Given this list of marker genes Mxi1, Mkrn1, Nfkbiz, H2ac6, Kcnab2, Kras, Ncdn, Mrps36, Pax6 (NCBI Gene Id 18508), Pop5, Slain1, Rev1, Kcnk3, Gpc4, Snord59a, Rps28, Ubc, H2ac8, Ubqln4, Iqcg, Actr3, Cracdl, Tha1, Znrf1, Steep1, Hcfc1, Sanbr, Six2, Itm2b, Smarcd1, Dcp2, Trip12, Axin2, 4930519P11Rik, Wnt2, 4930580E04Rik, Foxj3, Schip1, Spred1, Psmb4, Rcn1, Slc25a36, Stam, Kbtbd8os, As3mt, Mir100hg, Slco1a5, Prickle1, Ccdc142os, Ipo7, Cyth2 (cytohesin 2), Snhg3, Med13l, Gclc, Gcn1, Med16, Snhg15, Zfp148, Gm26562, Rps20, Tmem135, Rmi1, Zfp219, Ptpa, Lrrc58, Bend7, 6530409C15Rik, Hmox2, Fam53c, Gps2, Gatad1, G3bp2, Elk4, Gpld1, Adam9, Mir150, Srsf6, Syncrip, Lypd6b, Sinhcaf, Dffb, Aadat, Dhrs7, Marchf7, Tarbp2, A730035I17Rik, 2700078F05Rik (RIKEN cDNA 2700078F05 gene), Tshz3, Gstm5, Gm12694, Ccdc97, Foxo3, Gpd2, Btf3l4, Kmo, Pigm, Srsf2, Gm22579, Lamtor2, Rif1, Ptpra, Pcbd2, Gm22744, Snord12, Cfap43, H2bc6, Slc38a2, Pbx2, Arid1b, Ep400, Dennd1a, Sipa1l1, 1500026H17Rik, Gtdc1, Slc3a2, Emx2, Zfp524, 4933406P04Rik, 5330439K02Rik, Slc37a3, Jmjd1c, Mirlet7i, 1700084C06Rik (NCBI Gene Id 76618), Garem2, Phf8, Tunar, Numbl, Nfatc4, Zic2, Gm16249, Irak2, Zbtb34, Slc35d1, Tektip1, Birc6, Syce2, Zfx, Fbxo16, B3galt4, Ubqln1, Kank3, Zc3h12a, Pole4, Xiap, Mir6935, Pigl, Fignl1, Shisa5, Ppp1r10, Tet1, Oxsm, Dab2ip, Psmc3, Fance, Ehmt2, Smc5, Cenpu, Rom1, Arhgef11, Pde8a, Lsp1, Txnl4a, Set, Nadk, Mgat5b, Arhgap12, Gm9484, Prrg4, Umps, Prkd3, Gnptab, Prr14, Adnp, Btf3, Tdrd3, Fgfr2, Pdcd2l, Agps, 2310001K24Rik, Canx (calnexin), Gm15417, Tk1, Mest, Slc22a23 (solute carrier family 22, member 23), Sap25, Cdc42bpa, Mcl1 (NCBI Gene Id 99928), E130307A14Rik, Cfap276, Snord65, Paics, Fam163b, Rps10, Dio3, Ranbp17, Kdm2b, Chpt1, Gm6556, Epha2, Tfcp2l1, 1110025M09Rik, Mfsd4b5, Gm9884, Rybp, Dhx32, Srsf4, Mxra7, Rbm4b, Tob2, Zfp341, Rdh10, Fam78b, Cdx1 (caudal type homeobox 1), Mnt, Snora17, Gm23639, Gpr68, Dab2, Emx1, Ung, Psmb8, 1110059E24Rik, Ube2d3 (ubiquitin-conjugating enzyme E2D 3), Mir5627, Ttc8, Clasrp, Platr22, Zmym4, Hyal3 (NCBI Gene Id 235600), Gm11335, Arl2bp, Hectd2os, Ate1, Ext1, Gm25894, Pex2, Rpl21, Ctr9, Pdss2, Prmt3, Mtmr2, Cnot6, Clint1, Bcas2, Atxn2l, Nynrin, 4930520O04Rik, Slco5a1, Tnrc18, Arrdc3, Faah, Rad9b, Mroh8, Irak3, Maml1, Ints12, Insr, Etv5, Tyw5, Nudt1, Tmpo, Cisd1, Zfp326, Wtap, Vmp1, Limk1, Gm26590, Frmd8os, Shf, Parp12, Paqr8, Faap100, Tstd1, Brd2, Mmp25, 0610009L18Rik, Glcci1, Ppp1r35, Kansl3, Rcbtb1, Itsn2, Gm24016 (NCBI Gene Id 115490074), Stk38l, Fam120a, Nipa2, Pygo2, Fam135a, Acvr2b, Rps23rg1, Car7, Tusc2 (tumor suppressor 2, mitochondrial calcium regulator), Enkd1, Gm20544, Polr1b, Ep300, Ssbp2, Gm9958, Supt16, Kcnmb4, 3110031N09Rik, Gm10516, Zbtb38, Polr3g, Nln, Pcdh9, Agap3, Cyb5r1 (NCBI Gene Id 96900), Cnih2, Dleu2, Cdk4, Ino80dos, Tmem51os1, Fam162a, Hipk3 (NCBI Gene Id 15259), Ddx17, Snapc5, Rasal3, Slc23a3 (solute carrier family 23 (nucleobase transporters), member 3), Dexi, 4933431E20Rik, Flywch2, Sp1, Gm9828, Gm15270, Dhrs13, Gm10518, Kdm5b, Mcc, AU040320, Rmi2, Lamc2, Ccng2, Azi2, Pkp2, Sidt2, Slc12a2, Egln2 (NCBI Gene Id 97399), Ran, Zic4, C1ql1, Tinagl1, Sulf1, Sfxn5, Gm28047, Xpo1, Diaph1, Atp5mg, Sptbn1, Tm2d2, H2bc4, Adk, Tpm4, Ccdc9, Tfdp1, Tab1, Zfp24, Rnf19b, Fbxl3, Eif4enif1, 1110032F04Rik, Notch1, Iqank1, A230056P14Rik, Maf, Gatad2b, Lnx2, Acsl3, Rapgef2, Dnajb4, Psme1, Ftl1, Amotl1, Brd4, Arhgap21, Prrt2, Arid1a, Cul5, Neurl4 (neuralized E3 ubiquitin protein ligase 4), Slc25a4, Trib1, Dtx3, Dsg2, Dlgap4, Nod1, Abcc4, Picalm, Zfp407, Mapre1, Nhs, Cxxc4, Baiap2, Mgme1, Dock7, Med12l, Sgms1, Gm24452, Itgb1bp1, Gm16853, Map2k3, D17H6S53E, Alg1, Nol7, Gm43403, Siah2, Crot, Fam13b, 1700041G16Rik, Dusp1, Gm17501, Cnpy1, Bpnt2, Eapp (E2F-associated phosphoprotein), Socs5, Wwox, Oxct1, Fbxo30, Il33, Kcnq1, Gm24067, Npm3, Osbpl7, Gm24494, Prr14l, Tent4b, Snord45c, C920006O11Rik, Apoe, Hoxa4, Vamp5, Syt7, Tmem39b, Pdpk1, Slc30a9, Mettl5, Fblim1 (filamin binding LIM protein 1), Tulp4, Hnrnph1, Eif4h, Ggnbp2, Emx2os, Bcat2, Mir128-2, Ccnb1ip1, Rdm1 (RAD52 motif 1), Arid4b, Gm12279, Rps9, H2bc1, 4930432B10Rik, Atrx, Bcar3, Tor1aip1, Ermp1, Prrg1, Apex1, Utp3, Rplp0, Mecr, Zzz3, Adgrb3, Isca1, Ube2e1, Gm4419, P4ha1, Gm16253, Mrpl33, Prkacb, Defb44-ps, Kdsr, Bhlhe40 (basic helix-loop-helix family, member e40), Cirbp, 4933439C10Rik, Ptprj, Snx10 (NCBI Gene Id 71982), Tafa5, Bscl2, Adsl, Xpnpep3, Mplkip, Phykpl, Sgms1os1, Naa50, Psma4, Cnot1, Wrn (NCBI Gene Id 22427), Pxdn, Fermt2, Tcf12, Snrpe, Skil, Rere, Hes1, Apbb2, Gm57857, Slc10a7, Jarid2, Ugp2, Taf4, Rps19, Mex3c, Zfp82, Ncoa5, Pwwp3a, Sox5, Hes6, Zfp518a, Neat1, Chmp5, Rpl35a, Arid2, Ackr4 (atypical chemokine receptor 4), Wdr82, Cpsf3, Gnpda1, Dapk3, 3110082J24Rik, 4933440N22Rik, Ly6g6c, Gm16083, Gpr45, Plch1, Bloc1s2, Gm15631, Prcd, Zfp521, Zranb3, Hspa8, Atp2a2, U2surp, 5430416N02Rik, Hnrnpu, Cspp1, 1700113A16Rik, Bcl9l, Lrig2 (NCBI Gene Id 99941), Lemd3, Rabep1, Nid2, Ss18l1, Zcchc14, Amd1, Elapor1, Rgs6, Plcxd1, Znfx1, Washc1, Dnajb14, Elp5, Adamts10, Wasf1, Rabggtb, C030037D09Rik, Secisbp2, Gli1, Gm25878, 1810041H14Rik, Cux2 (cut-like homeobox 2), Rapgef6, Zfas1, Trp53cor1, Izumo2, Grcc10, Sclt1, Ahdc1 (AT hook, DNA binding motif, containing 1), Spmap1, Tmem181b-ps, Ptpn3, Naa12, Lrp12, Hapstr1, Rfc4, Atf7ip, Mir7036b, Snora65, Phactr1, Wdr5 (NCBI Gene Id 98832), 9330185C12Rik, Neurl2, Rnf146, Szrd1, Snord118, Cdk6, Rab26, Cnbd2, Brd10, Ptpn14, Pde8b, Rhbdf1, Gm11398, Acad9, Bin1, Ppp2r5e, Cdc42se2, Ptprr, Rbm47, Slc48a1, Scai, Thsd1, Midn (midnolin), Sra1, Gnb4, Cdh1, Kif20a, Med22, Arl6ip4, Isl2, Sec63, Chtf8, Gm22107, Foxk1, Man2a2, Ncoa2, Ninl, Gm16070, Sphk2, Gm5148, Cep104, 4930581F22Rik, Pan2, Ywhah, Gm10524, Ap3m1, Zmym3, Prrt1b, I830134H01Rik, Gm19569, Fbxw9, Meg3, Rusc2 (RUN and SH3 domain containing 2), Usp25, Zfp512b, Gpx4, Fut10, Smg5, 2410002F23Rik, Kif16b, Fbxo34, Pik3ip1, Eml3, Clcn3, Zfp384, Mex3b, Rhobtb3, Sspo, Gm23201, D130017N08Rik, Zfp609, Myl12a, Dnajc6, Rfk, B230354K17Rik, Aven, Zbtb16, Mir503hg, Galnt12, 1700086P04Rik, Scaf8, Mst1, Snord55, Mms22l, Cldn4, Ltbr, Bend5, Ttc41, BC005537, Man2c1, Polr1d, Supv3l1, Esrra, Nedd1 (NCBI Gene Id 17997), Eps15, Mybl1 (myeloblastosis oncogene-like 1), Nudt9, Reck, Acaca, Cplane1, Enc1 (ectodermal-neural cortex 1), Fhip2b, Slc35g1, Ywhaq, Ring1, Usp30, Mtcl1 (microtubule crosslinking factor 1), Hmga1, Spg11, Ribc2, Poldip3, Mrps18a, Tut7, Tbcb, Pls1, A730013G03Rik, Hexim2, Atp6v1a, Rnf26, Rab11fip2, Mir1247, Gm16701, Bltp3a, Sh3tc1, Ctnnb1, Slc6a8, Abi2, Malat1, Bcl7a (NCBI Gene Id 77045), Gsc2, H1f4, Gm15567, Paqr4, Lmln (NCBI Gene Id 239833), Cisd2, Acp6, Kdf1, Pbld2, Cd55, Mrm2, Caps2, 2500004C02Rik, Gapdh, Fahd1, Acvr1c, Gm15634, Ak4, Hsp90aa1, St7, Purg, Otx2, Ndufa7, Pik3c2a, Mir7687, Ankrd28, Spry1 (sprouty RTK signaling antagonist 1), Mllt6, Pim1, Unc5b, Purb (purine rich element binding protein B), Tmem168, Pakap, Zcchc4, Cerkl, Tmem229b, Evi5, Tmem121b, Mtdh, Mfsd4b3-ps, Fubp1, Dtnb, Arf1, Dll1, Syngr2, Snhg7os, Sugct, Mir9-3hg, Ipo5, Chd9, Lrsam1, Kcnj4, Rnps1, Lfng (LFNG O-fucosylpeptide 3-beta-N-acetylglucosaminyltransferase), Snx25, Cipc, Brd3, Sgcb (sarcoglycan, beta (dystrophin-associated glycoprotein)), Huwe1, A430035B10Rik, Gprc5c, Gm5447, 4933405L10Rik, 9230114K14Rik, Yipf2, Slc35b2, Ufsp1, 1700023H06Rik, Cux1, Timm21, 1600020E01Rik, Snora7a, Med1, Galnt2, Slc5a3, Neo1, Rtkn, Tpm1 (tropomyosin 1, alpha), Rpl13a, Gm25867, Qrich1, Dync2h1, Tpd52, Med29, Letmd1, Gm15723, Neurod1, 1700125H03Rik, Gm23301, Tbrg4, Iqcb1, Slc7a7, 2810433D01Rik, Thy1, Ocel1, Scmh1, Gm10244, Thap2, Sco2 (NCBI Gene Id 100126824), Slc44a1, Ccn1, Klhdc8a, Zfp628, Eif4e, Tenm1, Tbk1, Ube4b, Rbm22, Thra, Hsd17b4 (hydroxysteroid (17-beta) dehydrogenase 4), Zfp608, 1700028I16Rik, 9930012K11Rik, Rbm12, Akt3, Cep170b, Ppan, P2ry1, 1700045H11Rik, Greb1, Rcc1, Sh2b3, Helz, Zfp395, Gpr85, Foxp1, Cdkn1a, Ubb, Serinc3, Tle6, 4930430O22Rik, Rpl31, Snord72, Klf6, 6720483E21Rik, Slirp, Tsc22d4, Fam83h, Gm26330, Slc31a2, 2810408A11Rik, Sp3os, Patl1, Zfp710, Maip1, Cntnap2, Spr, Crebzf, Psip1, Ubtd2, Zfp597, Elac1, Suds3, Tssc4, Prdm15, Gm25855, Gpc6, Mtx3, Kmt2c, Bag1, Hnrnph3, Zfp423, Hexb, Scyl1, Rnf227, Epc1, Zfp335os, Mvb12b, 1700096K18Rik, Rtca, Pde5a, Mir762, Parp1, Paxbp1, Ndufb10, Zfp639, Ttc19, Polr2a, Bud13, Samd4, Bmf, Polr2i, Snord45b, E130018N17Rik, Gm11175, 4931440P22Rik, Tsku, Maml3, Col11a2, Depdc7, Aff1, Wbscr25 (Williams Beuren syndrome chromosome region 25 (human)), Igf2bp2, Smarce1, Upp2, Mfsd11, Swsap1, Rhobtb1, Wwp1, Hcfc2, Slc4a2, Epb41l4aos (NCBI Gene Id 69749), Ccn2, Slc4a11, Gm12743, Tead1, Atxn2, Donson, Gnas, Raver2, Smim14, Pank2 (pantothenate kinase 2), Adgrl2, Gm12474, C330002G04Rik, Alyref2, Inha, H4c1, Paox, 4930509H03Rik, Memo1, Rpl12, Ppp4r1, Lif, Cd164, Thoc3, Btg3, Ppip5k1, Snap91, Tmem191, H2ac11, Ash2l, Pabpc4, Esco1, Tlnrd1, Zfa-ps, Mir219a-1, Arhgap11a, BC031181, Gm24453, Atrnl1, Smad7, Gm16233, Crlf3, Syngr1, Tgfb1, 1700008O03Rik, Cdkn2aipnl, Gorasp2, Wrap53 (NCBI Gene Id 216853), Soat1, Aebp2, Fgf9, Mettl23, Gt(ROSA)26Sor, Efna4, Id3, Plcg1, E2f3, Epn1, Mrpl15, Setd5, Gm13375, Mapk9, Poln, Dynlrb1, Ppp1r15a, 2310005A03Rik, Agpat2, Atf7ip2, Gm10785, Mtg1 (mitochondrial ribosome-associated GTPase 1), Snord42b, Pard3, Gm14393, Rpl3, Plekha8, Mysm1, Fam168b, Bcl7c, Atp8b1, Azin2, Gm6658, Pccb, Mpc1, Ccnb2, Srp72, Sos1, Dcbld1, Xpa (NCBI Gene Id 22590), 2610005L07Rik, Ctdspl2, Bsg, Glyr1, Spred2, Tcf15, Mir1894, Fa2h, Ncor1, Snord58b, 4931406C07Rik, Zbtb7b, Inpp5a, Mtrfr, Smim1, Ccne2, Hsd17b8, Fbxo36, Celf2, Eif1, Chsy1, AU041133, Gtf2b, Adipor1, Caprin1, Rgl2, Utp14b, H2bc15, Gpr153, Nadk2, Ube2e3, Bsdc1, Zfp704, Sema6a, Cbx3, Gm23969, Mettl5os, Fxr2, Gm7160, Foxn3, Unc5a, Gm20609, Usp3, Ints10, Cntn4, Spry2, Arap2, Wipf2, Gm16124, Atp5f1b, Casd1, Ece1, Gm11627, Stamos, Rcl1, Vps29 (VPS29 retromer complex component), Man2c1os, Gab2, H3c10, Rpp21, Trap1, Ino80d, Atf7, Kmt5b, Ppp1r2, Hps5, Osgin2, Ctdnep1, Klhdc1, Sox2ot, Sephs1, Cdip1, A930001C03Rik, Taf4b (NCBI Gene Id 72504), Enah, A930032L01Rik, Plekha4, Cdc42ep3, Pafah2, Ppa2, Tbl1xr1, Ppp1cc, Rimoc1, Large1, Slc27a3, Dcc, Rpl18, Cdc40, Nrf1, Haus4, 2610035F20Rik, Rbm39, Poglut3, Capn7, Plk2, Lypla1 (NCBI Gene Id 18777), 4930592C13Rik, Gm11240, Dram1, Kcp, Gm9530, Srgap1, Klf10, Coro6, Irgm1, Kdm1a, Gm15860, Jpt2, Snord2, 2410006H16Rik, H2bc18, Relb, Crebl2, Rps27l, Zfp281, Cnot6l, Aplp1, Flywch1, Zdhhc6, Mov10, Rbpj, Coq3, Atic, Gm13033, Gm27003, Shld2, Gm15420, Htr7, Mpdz, Gm16740, Klf15 (Kruppel-like transcription factor 15), Ice1, Klhl35, Mettl1 (NCBI Gene Id 70215), Mapk11, Snora73b, Ngly1, Msh4, Clec12a, Eed (NCBI Gene Id 16759), Timmdc1, Tenm4, Fcor, Gramd1a, Atf5, Zmiz1, Foxp4, Klhl2, Arhgef12, Rpl18a, Epn3 (epsin 3, NCBI Gene Id 71889), Tmsb10, Tmem238, Kbtbd2, Pgls, Ndufs6, Ash1l, Tiparp (TCDD-inducible poly(ADP-ribose) polymerase), Rhbdd3, Prrc2a, Kcmf1, Iqsec1, Sdhaf2, Snord43 (small nucleolar RNA, C/D box 43), Mmgt2, Hdgfl2, Lmo4, Hagh, Gm13162, Skic8, Gm4707, Hspa9, Maz, Psma7, Arhgap42, Srgap3, Crem, Ctsa (cathepsin A), Uxs1, Slc15a4 (solute carrier family 15, member 4), Ddr1, Cdc73, Dap, Mix23, Mllt10, Guf1, Sec24d, Mir8114, Ttc39d, Sec11a, Jund, Adora2a, Mettl17, Snhg5, Commd7, Sp3, Nsd3, Myl6, Scrib, Cip2a, Sh3glb1, Sec24b, Spaca6, Vti1a, Vps37d, Nsmaf, Anp32a, Ccnk, Hmgn1, Gm23143, Map4k4, Rspo1, Fiz1, Paip2, Itga5, Nae1, Cops7a, Tyw3, Smchd1 (NCBI Gene Id 791279), Dnajc1, Ccdc6, Kcnmb4os2, Atxn7l2, Gm14004, Klhl9, Rprd2, Rpl26, Tmem54, Tiprl, Cspg5, Rab6b, Eef1akmt3, Lrrc8d, Add1, Wnt2b, H2bc8, Ppat, Gramd2a, Mafa, Igf2bp3, Utp4, Gm15477, Trhde, Tsnax, Polg, Cbfb, Lnpep, Qser1, Gm14634, Tab2, Dipk1a, Mylip, Rell1, Rad54l2, B130046B21Rik, B3gnt7, Cdyl, Snhg6, Gm15969, Tmem79, Uba52, Efnb3, Snora81, Lig4, Oxct1as (NCBI Gene Id 414066), Cd2bp2, Bptf, Rps18, Wdr3, Zfp106, B4galt7, Zcchc2, Cryz, Shb (NCBI Gene Id 230126), Eef1a1, Ddx21, Spata33, Gm16069, Mir6991, Mageb3, Cln8, Scd2, Dhx9, Tti2, 1810019D21Rik, Lpcat4, Yars1, Uckl1, AI480526, Pds5a, Dzip3, Grsf1 (G-rich RNA sequence binding factor 1), Kpna2, Rpl10a, Snrpg, Irf2bpl, Tada2a, Trim33, C330018D20Rik, Mtf2, Mir5135, Rpl5-ps2, Reno1, D3Ertd751e, Sema6b, Syde1, Zfp60, Mbtd1, Rbl1, Nrp2, Gm25939, Kmt2a, Ddx59, Plpp5, Nubp1, Mphosph9 (M-phase phosphoprotein 9), Papola, Trak2, Ccdc88a, 1700066J03Rik, Wdr48, Fam3c, 4930405A21Rik, Unc119, 4930599N23Rik, Kank2, Ints4, Tnpo2, Zfp36, 1110002J07Rik, Racgap1, Tcte2, Mir6936, Gm20522, Gli3, Cltc, Mob4, Zswim7, Eif4a2, Paip1, Ttll4, H2ac15, Sgtb, H2ac1, Tspyl3, Flvcr1, Rpl34, Mtpn, Zfp11, Casz1, Agap1, Sulf2, Nfkb1, Gse1, A430018G15Rik, Celf1, Amigo2, Shank3, Hnrnpr, Mcm10, Eif4e1b, Ephb2, Mir8092, Rasef, Mtres1, Prkar1b, Rps8, Gm11696, Nudcd1, Dchs1 (NCBI Gene Id 73159), Wac, Kpnb1, Mta3, Adss1, Fndc3b, Gpr176, Zfp367, Mir125b-1, Csnk1d, Agap2, 2510009E07Rik, Agrn, Adgrl3 (NCBI Gene Id 74495), Gm10472, Gigyf2, Entrep3, Wls, Naa25, Snord22, Osbpl5, Gm23455, Kdelr2, Zfp746, Camta2, Lamb2, Prep (NCBI Gene Id 28116), Surf6, Jak1, Gdap2, Mesd, Glis2 (GLIS family zinc finger 2), Car14, Exoc2, Snora9, Scamp3, Pigt, Cep72, 2200002D01Rik, Zfp629, Morc2a, Isg20, Man1a2, Gm26676, St13, Csrnp2, Gm2449, Larp1, Nectin3, Hsf3, Trpm4, Ism2, Catsperg1, Plcb4, Zwilch, Smc3, Naa35, Tmem64, Arhgap27, Platr9, Tubb5, Gm16845 (predicted gene, 16845), Zcwpw2 (zinc finger, CW type with PWWP domain 2), Eif2s3y, Pdlim5, Adgrl1, Shank1, Zc3h4, Agbl5, Tor1b, Bag4, Ccdc158, Mcu, H2bc13, Zfp236, Pnrc1, Ptpre, Wdr12, 4930539J05Rik, Chst8, Cul7, Cdk5r1, 4921531C22Rik, Acbd4, Dmxl1, Tbx3, Bean1, Gm15706, Rcbtb2, Fitm2, Matr3, Atp8b2, Pagr1a, Teddm2, Acvr1, Jade1 (jade family PHD finger 1), Nfe2l3, Stum, Mir203 (microRNA 203), Gtf2i, Eml2, Top6bl, Snx5, Spint1, Bzw1, Gm2824, 2810021J22Rik, Tug1, Tbkbp1, Naa60, Tent5c, Zfp1006, Taf1d, Pafah1b1 (NCBI Gene Id 94322), Rap2a (RAS related protein 2a), Furin, Dlgap3, Morf4l1, Raph1, Snora73a, Ddx47, Hsp90b1, Rnf139 (NCBI Gene Id 75841), Cep57, Zfp513 (zinc finger protein 513), Taf10, Svop, Adgra2, Paf1, Fxr1, Rps14, Cpne1, Pde4b, Actg1, Adamtsl4, Pphln1, St3gal4, Gm12100, Spmip7, Lrfn4, Hs2st1, Gabbr1, Lrrc75a, Tkt, Comtd1, Gm29417, Magohb, Ranbp1, Kansl1l, Crbn, Adgrv1, Myl12b, Mrps6, Rpl23a, Mfap3l (NCBI Gene Id 71408), Klf7, 6430573P05Rik, Atn1, Cimip2a, B3galt1, Srsf3, Lbh, H2ac14-ps, Kcnq5, Tmem33, Nectin1, Gm4219, Lpgat1, Mrgbp, Dusp7, Frg2f1, Gm2093, Gm4221, 4930483J18Rik, Arx, Bbc3, Capzb, Rab3ip, Zc3h10, Ago3, Trnau1ap, Snx19, E330020D12Rik, Rel, Pcbp2, 9330162012Rik, Tjap1, Gpat3, Mn1, Cbfa2t3, Bnc2, Usp19, Srd5a3, Filip1l, Ccna2, Slc20a1, 2310010J17Rik, D630045J12Rik, Gtf2a2 (general transcription factor II A, 2), H2af-ps2, Nab1, Stmn1, Wdr44, Arl4aos, Elk1, Snord32a, Dnai1, Ccdc159, Rfx8, Rpl7a, Lemd1, Gm25794, Mdk (NCBI Gene Id 17242), A330035P11Rik, Gm24201, Slc25a10, Ltbp4, Wdr4, Gm31266, Smad4, Ap5b1, Mkrn2, Pias2, Coasy, 9230116N13Rik, Ogdhl, Ints15, Cdkl2, Nphp4, Rnf123, Gm13778, Evpl, Kat6a, Arl4a, Rpn2, Pcyt1a, Hmgb1, Satb1, Ctbp2, Thumpd1, Mir219c, Mrps18b (NCBI Gene Id 96968), Ypel2, Obsl1, B3glct, Msi2, Ube2a (ubiquitin-conjugating enzyme E2A), Bcl6, Lrp3, Dclk2, Kansl1, Gid8, Actr3b, Heph, Snord83b, Steap2, Cacng8, Psmd9, Zkscan17, Pik3c2b, Hnrnpl, Mrpl20, Esrp2, Nbn, C130036L24Rik, Baz2a, Igdcc3, Haus3, Snord49b, Hdgf, Ahcyl1, Cep55, Gm26614 (predicted gene, 26614), Prdm11, Rhbdl1, C2, Trim36, Cacna1h, Slc27a2, Ptprd, Ncam1, Rdx, Smad5, Krtap31-3, Relt, Tm2d1, Scap, Sltm, Lrrc1, Mir5121, Etl4, Pcbp1, Afmid, Ddi2, Rims2, Trmt2a, Rasa2, Dennd4b, Ankrd17, Lsm14a, Rprm, Rara, Zranb2, Tm9sf2, Ppp1r12a, H3c8, Gm15559, Rnf103, Gbe1, Acvr2a, Mex3a, Arnt2, Tmem131l, Phldb2, Usp2, Micos10, Tmem229a, Adamts9, Gm23130, Nudt5, Rnf220, Tapbp, Rex1bd, Gm10190, Cdc123, Mir1949, Atp8a1, Tfap2c, Baz2b, Dgat2, D330041H03Rik, Pibf1, Cds1, Junb, Glul, Foxk2, Zfp280d, Lsm1, H3c2, Slc16a9, Tob1, Ppp1r9b, Ankrd6, Gtf2h1, Nat10, Chek1, Smc1b, Zcrb1, Lrfn1, Phactr3, Ap5m1, Dnmt3a, Pak5, Tdh, Usp53, Osgep, Afdn, Mir17hg, Rpl32, Nfkbid, S100pbp, Rnf111, Cep95, 4930527J03Rik, Sod1, Peli1, Aurkaip1, Yeats4, Dap3, E130311K13Rik, H2az1, Pigz, Ccnl1, Hsf5, Acss3, Plekhg3, Gm16041, Cited2, Hoxc5, Eaf2, Phip (pleckstrin homology domain interacting protein), Orai3, Fyn, Pdcd2, Srsf11 (serine and arginine-rich splicing factor 11), Zfp532, Cxxc5, Fbxw2, Pea15a, Ap1g1 (NCBI Gene Id 52301), Map2k6, Nck2, Mycbp2 (NCBI Gene Id 97940), Mir6921, Cand1, Gm40190, AY074887, Zfp507, Necab3, Als2, Rasgrp2, Phf1, 5730455P16Rik, Rap1gds1, Dcaf5, Fam220a, Trim8, Nipsnap2 (nipsnap homolog 2), Mcts2, Mex3d, Iba57, Snord49a, Dna2, Rbbp8nl, Uckl1os, Fus, Ghr, E230029C05Rik, here is a description of the gene set: Mouse Gene Set: DPF2_TARGET_GENES studied in species Mus musculus Genes containing one or more binding sites for (Dpf2) in their promoter regions (TSS -1000,+100 bp) as identified by GTRD version 20.06 ChIP-seq harmonization. from publication Yevshin I, Sharipov R, Kolmykov S, Kondrakhin Y, Kolpakov F (PMID 30445619)